The following is a description of a gene set: Human Gene Set: HP_RENAL_TUBULAR_ACIDOSIS studied in species Homo sapiens Acidosis owing to malfunction of the kidney tubules with accumulation of metabolic acids and hyperchloremia, potentially leading to complications including hypokalemia, hypercalcinuria, nephrolithiasis and nephrocalcinosis. Renal tubular acidosis, and this is the list of marker genes: VIPAS39, VPS33B, EPG5, PHKA2, TAOK1, RMND1, CLCNKB, NOTCH2, FAH, SURF1, SLC2A2, PHKG2, SLC4A1, CAD, NADK2, COA8, ATP6V0A4, NDUFAF6, FBXL4, PC, PIGA, ATP6V1B1, BCS1L, GATA3, SLC34A1, ALDOB, CPT1A, SLC7A7, CA2, RRM2B, HNF4A, UQCC2, IVD, MT-TL1, GATM, MT-ATP8, SLC4A4, JAG1, POLRMT, KYNU, CTNS, EHHADH, CLDN16, PHKB, OCRL, SLC12A3, MT-TN, HNF1B